The following is a description of a gene set: Reactome Pathway: Activation of BMF and translocation to mitochondria In healthy cells, BMF is bound to the myosin V motor complex through its interaction with DLC2. UV irradiation or anoikis induces MAPK8 (JNK) to phosphorylate Dynein Light Chain 2 (DLC2) to release BMF. studied in species Homo sapiens part of: Activation of BH3-only proteins, and this is the list of marker genes: BMF, MAPK8, DYNLL2